Given this list of marker genes CPZ, CMA1, GGT2P, ANPEP, GCLC, ERAP1, ECE1, DNPEP, CHAC2, CPM, GGT6, HAGH, GSS, NFE2L2, ABCB9, CTSH, LANCL2, SLC1A2, PCSK1, NPEPPS, MME, MGST2, CPA4, CPQ, ENPEP, BDH2, MMP7, CPE, THOP1, LANCL1, ACE, GGT1, NPEPPSP1, TRHDE, CPD, SLC7A11, GGT3P, NLN, LVRN, ELANE, DMD, SLC1A1, AASDH, GGT5, LNPEP, LANCL3, ERAP2, CHAC1 (NCBI Gene Id 79094), PCSK5, GCLM, FURIN, PAM, CPN1, LTA4H, GGT7, IDE, ADAMTS13, NAALADL1, TAPBP, BLOC1S6, LGALS4, AEBP1, PGLYRP2, MIPEP, TPP1, here is a description of the gene set: Human Gene Set: GOBP_PEPTIDE_METABOLIC_PROCESS The chemical reactions and pathways involving peptides, compounds of two or more amino acids where the alpha carboxyl group of one is bound to the alpha amino group of another. studied in species Homo sapiens